The following is a description of a gene set: Human Gene Set: MIR1276 from publication Chen Y, Wang X (PMID 31504780) species: Homo sapiens Genes predicted to be targets of miRBase v22 microRNA hsa-miR-1276 in miRDB v6.0 with MirTarget v4 prediction scores > 80 (high confidence targets)., and this is the list of marker genes: GRM6, SPIN1, PNMA2, BLCAP, AHCYL1, RBP3, UNC5C (unc-5 netrin receptor C), GRIN3A, AP2B1, ATF7IP, SPAG9, TMEM229B, CREBZF, DDX5, ADAM7, LPIN2, COPS5, SOD2, CTNND2, TNIK, EBF2, ITGBL1, BCL2, ZNF516, FEM1C, RSKR, C21orf91, OC90, N4BP2L1, RCAN2, GPR15, FOXO1, SDE2 (SDE2 telomere maintenance homolog), HPN, BNIP2, ERLIN1, PDHA1, ATL3, CDK19, FANCC, IRF2BP1, DGKI, PTPN11, PIK3C2B, NFKBID, ARHGEF7, KCNS2, CRYBG3, CWC25, ZNF695, FBRSL1, ERBB4, OSTM1, KCNQ3, USP28, LPCAT2, CCDC7, CHMP2B, RMC1, NOL11, ANGEL2, PPP2R5C, MAP1A, ADCY9, ZNF800, ALCAM, CASP7, ATRNL1, IMPACT (impact RWD domain protein), CDC27, SEMA6A, PATZ1, WT1, BRPF3, CCDC91, WDR64, DROSHA, RBM39, C3orf70, NMB, LACTB, PCDH19, CASZ1, AFF4, CELF4, ST8SIA3, PGAP4, PNISR, ZBTB21, ARHGEF12, RORA, RBM24, TRPC6, CLMN, SYT1, GET1, KCNK2, TOP2B, CADM2, IKZF1, RBMS1, THSD4, DPY19L3, ZFYVE16, OMD, JMY, CNTNAP2, PHYH, RIMKLA, CHDH, USP9X, MXI1, CXCR3, GPBP1, PIK3CG, PKHD1L1, VTA1, PIGG, MARS2, PIK3CB, ZNF28, DHDDS, RYR2, CTNND1, BPY2C, KCNK1, ELMOD2, TPM3, COG5, PARG, SLC25A30, ZBTB20, TRDN, PPIP5K2, SLC25A17, BPY2B, HIF1A, SINHCAF (SIN3-HDAC complex associated factor), JAK1, ARFGEF2, CARF, PLD6, HYLS1, SYT16, ITGB3BP, SLC1A2, ITM2A, ZBTB18, TMEM254, RPS6KB1, STK39, C17orf75 (chromosome 17 open reading frame 75), PTGES3L, LRRC7, C2orf76, PTPRD, LGI2, ZRANB3, KAT6A, F2RL2, SLC25A32, BCLAF3, GADL1, INTS2, RAPSN, BPY2, SMG7, GPATCH2L, CCDC60, CCDC190, MMP16, PTP4A1, MARK1 (microtubule affinity regulating kinase 1), CDH12, BRD1, FCHO2, NAALAD2, PIP4K2C, GXYLT1